Given this list of marker genes SLC24A1, SLC9A5, SLC17A7, SLC9C1, SLC9A1, SLC24A3, SLC9A8, SLC17A6, SLC9C2, SLC9A9, SLC9A3, SLC9A6, SLC9A7 (solute carrier family 9 member A7), TMCO3, SLC24A2, SLC9A2, SLC9A4, SLC24A5, SLC24A4 (solute carrier family 24 member 4), here is a description of the gene set: studied in species Homo sapiens Human Gene Set: GOMF_SOLUTE_POTASSIUM_ANTIPORTER_ACTIVITY Catalysis of the active transport of a potassium ion across a membrane by a mechanism whereby two or more species are transported in opposite directions in a tightly coupled process not directly linked to a form of energy other than chemiosmotic energy.